The following is a description of a gene set: Binding to the plus end of a microtubule. Human Gene Set: GOMF_MICROTUBULE_PLUS_END_BINDING studied in species Homo sapiens, and this is the list of marker genes: CLIP3, KIF18A, CLIP2, CLIP1, DST, MAPRE2, MAPRE3, FBXW11, PAFAH1B1, CLASP1, STIM1, CLIP4, KNSTRN (NCBI Gene Id 90417), CKAP5, TBCB, MAPRE1, APC, TTBK2, CLASP2, KIF2C, NUMA1